Given this list of marker genes Gamt, Ckmt2, Gatm, Slc6a11, Ckmt1, Slc6a7, Slc6a8, Ckm (NCBI Gene Id 12715), Ckb, Slc6a12, here is a description of the gene set: Creatine metabolism Mouse Gene Set: REACTOME_CREATINE_METABOLISM species: Mus musculus